The following is a description of a gene set: Any process that modulates the frequency, rate or extent of gene expression as a consequence of a process in which a signal is released and/or conveyed from one location to another. Mouse Gene Set: GOBP_SIGNAL_TRANSDUCTION_INVOLVED_IN_REGULATION_OF_GENE_EXPRESSION studied in species Mus musculus, and this is the list of marker genes: Traf2, Fgf8 (fibroblast growth factor 8), Pdgfra, Parp1, Msx2, Fgf5, Tbx6, Traf5, Gata4, Mesp1, Foxa2, Srsf1 (NCBI Gene Id 70724), Neurod1, Mesp2, Cer1, Gsc, Sox17, Traf3ip2, T, P2ry1 (NCBI Gene Id 18441), Epcam, Hnf4a, Smad2, Edn1, Smad3, Msx1, Pax6, Dand5